The following is a description of a gene set: Human Gene Set: GOMF_LIPID_KINASE_ACTIVITY species: Homo sapiens Catalysis of the phosphorylation of a simple or complex lipid., and this is the list of marker genes: AGK, DGKD, PIK3CA, PIP4K2A, PI4K2B, PIK3CG, PIK3R1, PI4K2A (NCBI Gene Id 55361), PIK3R6, PIK3CD, PIP5K1A, PIP4K2B, PIK3R3, SPHK2, CERK, PIP5KL1, PIK3C2G, DGKQ, PIP5K1C, SPHK1, PIPSL, PIK3C3, DGKG, DGKH, DGKA, PIP4K2C (phosphatidylinositol-5-phosphate 4-kinase type 2 gamma), PIK3R2 (phosphoinositide-3-kinase regulatory subunit 2), DGKB, PIKFYVE, IPMK, ATM, CERKL, PI4KB, DGKK, PI4KA, PIK3R5, PIK3C2A, CCKBR, DGKE, DGKZ (diacylglycerol kinase zeta), PIP5K1B, PIK3C2B, DGKI, PIK3CB (phosphatidylinositol-4,5-bisphosphate 3-kinase catalytic subunit beta)